The following is a description of a gene set: species: Mus musculus from publication Hu T, Gibson DP, Carr GJ, Torontali SM, Tiesman JP, Chaney JG, Aardema MJ (PMID 15120960) Genes discriminating between direct (cisplatin, MMS, mitomycin C) and indirect (paclitaxel, hydroxyurea, etoposide) acting genotoxins at 4 h time point. Mouse Gene Set: HU_GENOTOXIN_ACTION_DIRECT_VS_INDIRECT_4HR During the safety evaluation process of new drugs and chemicals, a battery of genotoxicity tests is conducted starting with in vitro genotoxicity assays. Obtaining positive results in in vitro genotoxicity tests is not uncommon. Follow-up studies to determine the biological relevance of positive genotoxicity results are costly, time consuming, and utilize animals. More efficient methods, especially for identifying a putative mode of action like an indirect mechanism of genotoxicity (where DNA molecules are not the initial primary targets), would greatly improve the risk assessment for genotoxins. To this end, we are participating in an International Life Sciences Institute (ILSI) project involving studies of gene expression changes caused by model genotoxins. The purpose of the work is to evaluate gene expression tools in general, and specifically for discriminating genotoxins that are direct-acting from indirect-acting. Our lab has evaluated gene expression changes as well as micronuclei (MN) in L5178Y TK(+/-) mouse lymphoma cells treated with six compounds. Direct-acting genotoxins (where DNA is the initial primary target) that were evaluated included the DNA crosslinking agents, mitomycin C (MMC) and cisplatin (CIS), and an alkylating agent, methyl methanesulfonate (MMS). Indirect-acting genotoxins included hydroxyurea (HU), a ribonucleotide reductase inhibitor, taxol (TXL), a microtubule inhibitor, and etoposide (ETOP), a DNA topoisomerase II inhibitor. Microarray gene expression analysis was conducted using Affymetrix mouse oligonucleotide arrays on RNA samples derived from cells which were harvested immediately after the 4 h chemical treatment, and 20 h after the 4 h chemical treatment. The evaluation of these experimental results yields evidence of differentially regulated genes at both 4 and 24 h time points that appear to have discriminating power for direct versus indirect genotoxins, and therefore may serve as a fingerprint for classifying chemicals when their mechanism of action is unknown., and this is the list of marker genes: Ppie, Dvl2 (dishevelled segment polarity protein 2), Acaa2, Sox1, Rsrp1, Nfkbia, Mcl1, Lrch4, Gzmm, Pitpnb, Clk2, Pfkm, Actb, Cd28, Kras, Sdhaf1, Arf5, Syt2, Atp6v0a2, Dmbt1, Ift46, Slc1a2, Nono, Ackr4, Bach1, Vwf, Tmem230, Mak, Nrp1, Ubc, Ssbp2, Kcnj2, Smc4 (structural maintenance of chromosomes 4), Zeb1, Loxl1, Nr1h2, Snai2, Icam2